The following is a description of a gene set: studied in species Homo sapiens from publication Chen Y, Wang X (PMID 31504780) Genes predicted to be targets of miRBase v22 microRNA hsa-miR-6891-3p in miRDB v6.0 with MirTarget v4 prediction scores > 80 (high confidence targets). Human Gene Set: MIR6891_3P, and this is the list of marker genes: NETO1, VWC2, CNR2, FAM168A, TINF2 (NCBI Gene Id 26277), STK3, ATRNL1, MSL2, CCAR1, RIC3, ARHGEF33, CLIP4, CERS6, CEP41, PTPRT, C1orf21, GFI1 (growth factor independent 1 transcriptional repressor), KCTD20, FLT1, CUL5, RAB3B, HIF1AN, NPTN, NUDT13, MON1B, RRP15 (ribosomal RNA processing 15 homolog), ADAM23, DCX, SYT1, PCYT1A, POLE4, VDAC2, SIX1, AGBL4 (AGBL carboxypeptidase 4), ZNRF3 (NCBI Gene Id 84133), SMARCAD1, SNX20 (NCBI Gene Id 124460), ANGPT2, BECN1, SEPTIN4, DPY19L3, RNF168, PPT1, IFIT5, RNMT, OLIG2, HNRNPDL, UBXN4, PIK3R3 (NCBI Gene Id 8503), RUNDC3B, LEMD3, ONECUT2, PRKCI, SPRY2, CREB1, ALG6, AMOT, MICU1, TTL, CAMKV, TMEM221, KCTD3 (NCBI Gene Id 51133), KPNA5, ABCC3, APPBP2, DENND4A